The following is a description of a gene set: species: Homo sapiens A type of carcinoma of the kidney with origin in the epithelium of the proximal convoluted renal tubule. Human Gene Set: HP_RENAL_CELL_CARCINOMA Renal cell carcinoma, and this is the list of marker genes: TSC2, NRAS, ARMC5, PBRM1, NOD2, BAX, BUB1, MINPP1, TFE3, KIF1B, PTEN, TSC1, KDM1A, SDHAF2, TP53, HABP2, CCND1, DCC, PIK3CA, TLR2, SDHC (NCBI Gene Id 6391), IFNG, BAP1, HNF1B, LMNA, PTPRJ, TMEM127 (NCBI Gene Id 84178), BRAF, AAGAB, SDHA, KEAP1, AXIN2, CTNNB1, RAD54B, MET, OGG1, RNF139, PRCC, RET, BUB1B (NCBI Gene Id 701), MAX, VHL, SRC, FGFR3, MDH2, SLC25A11, AURKA, DICER1, USF3, MLH3, FLCN, SDHB, DLST, STK11, AKT1, PRDM10, PDGFRL, DLC1, PLA2G2A, COL14A1, CDC73, SEC23B, NF1, PTPN12, FOXE1, APC, GNAS, MCC, EP300, FH (NCBI Gene Id 83748), HNF1A, KLLN, SDHD